Given this list of marker genes DMGDH, SARDH, ALDH7A1, BHMT, CHDH, SLC44A1, here is a description of the gene set: Choline catabolism studied in species Homo sapiens Human Gene Set: REACTOME_CHOLINE_CATABOLISM